Given this list of marker genes Aqp1, Ppp3ca, Tac4, Fgf10, Oprk1 (opioid receptor, kappa 1), Negr1, Neurog1, Tifab, here is a description of the gene set: Mouse Gene Set: GOBP_REGULATION_OF_SALIVA_SECRETION Any process that modulates the frequency, rate or extent of the regulated release of saliva from a cell or a tissue. studied in species Mus musculus